The following is a description of a gene set: Transforming growth factor-beta (TGFbeta)-activated signalling pathways can lead to apoptosis, growth arrest or promotion of malignant behaviour, dependent on cellular context. The molecular mechanisms involved in TGFbeta-induced apoptosis remain controversial; although changes in gene expression are thought to be pivotal to the process, several different candidate apoptotic initiators and mediators have been proposed. Smad4, a critical component of the TGFbeta-induced transcriptional machinery, is shown here to be essential for induction of apoptosis. Gene expression analysis identified the proapoptotic Bcl-2 family members, Bmf and Bim, as induced by TGFbeta, dependent on both Smad4 and p38 function and the generation of reactive oxygen species. TGFbeta-induced Bmf and Bim localize to cellular membranes implicated in apoptosis. Inhibition of the TGFbeta-induced expression of both these proteins together provides significant protection of cells from apoptosis. The TGFbeta-triggered cell death programme thus involves induction of multiple BH3-only proteins during the induction of apoptosis. Mouse Gene Set: RAMJAUN_APOPTOSIS_BY_TGFB1_VIA_SMAD4_DN Apoptotic genes dependent on SMAD4 and down-regulated in AML12 cells (hepatocytes) after stimulation with TGFB1. species: Mus musculus from publication Ramjaun AR, Tomlinson S, Eddaoudi A, Downward J (PMID 16909112), and this is the list of marker genes: Dapk1, Casp7, Sgpp1, Atm, Bcl2l1 (NCBI Gene Id 12048), Tnfrsf21, Mapk8ip1, Eya2, Egln3, Tnfrsf10b